The following is a description of a gene set: Mouse Gene Set: CUI_TREG_IL1A_RESPONSE_DN Cytokines mediate cell-cell communication in the immune system and represent important therapeutic targets. A myriad of studies have highlighted their central role in immune function, yet we lack a global view of the cellular responses of each immune cell type to each cytokine. To address this gap, the authors created the Immune Dictionary, a compendium of single-cell transcriptomic profiles of more than 17 immune cell types in response to each of 86 cytokines (>1,400 cytokine-cell type combinations) in mouse lymph nodes in vivo. A cytokine-centric view of the dictionary revealed that most cytokines induce highly cell-type-specific responses. For example, the inflammatory cytokine interleukin-1β induces distinct gene programmes in almost every cell type. A cell-type-centric view of the dictionary identified more than 66 cytokine-driven cellular polarization states across immune cell types, including previously uncharacterized states such as an interleukin-18-induced polyfunctional natural killer cell state. Genes negatively differentially expressed in cell type: Treg upon treatment with cytokine: IL-1α in mouse lymph nodes in vivo. from publication Cui A, Huang T, Li S, Ma A, Pérez JL, Sander C, Keskin DB, Wu CJ, Fraenkel E, Hacohen N (PMID 38057668) studied in species Mus musculus, and this is the list of marker genes: Shisa5, Nav2, Sh3bgrl3, Tmbim4, Ifi203, Ctss, Rgs10, Lbh, Cd44, St8sia4, Tnik, Jun (jun proto-oncogene), Dbp, Clec2d, Nsg2, Tspan32, Cyth4, Dnmt3a, Trbc2, Arhgef1, Lsp1, Tsc22d4, Ypel3, Ptpn18, Id3, Gm2a (NCBI Gene Id 552880), Dgkz (diacylglycerol kinase zeta), S100a6, Zbtb7b, Tmsb10, H1f2, Acap1, Tgfbr1, Pou2f2, Crip1, Btg2, Arhgap45, Mbp, Fxyd5, Capg, S100a11, Nrp1, Acyp1, Rac2, Bin2, S100a10, Limd2, Tesc, Lck, Hspa1b, Pycard (PYD and CARD domain containing), Ccdc88c, Bcl2, Ltb, Ptpn6, Sh3kbp1, Ipcef1, Ptms, Msn, Itgal, B4galnt1, Apol9b, Mbnl1, Ptpn7, Ikzf2, Vim, H2aj, Macf1, Hnrnpf, Pfn1 (profilin 1), Dguok, Coro1a (NCBI Gene Id 16902), Lamtor4 (NCBI Gene Id 66096), Hivep3, Ahnak, Rasgrp1, Larp1b, Hsd11b1, Abcg1, Pglyrp1, Mxd4, Lgals1, Adgre5, Ms4a6b, Grap, Ptger4, Rgs3, Fos, Rasgrp2, Smpdl3a, Ccnd2, Itgae, Cd69, Cd83, Ms4a4b, Cdc42ep3, Rad50, Capn3, AI504432, S100a4, Gprin3, Ssbp3, Cd28 (CD28 antigen), Cd3g, Apbb1ip, Rabgap1l, Septin9, Ankrd44, Socs2, Vasp, Cd52, Anxa6, Timp2, Tespa1, Stap1, Smc6, Csk, Itgb7, Itgb1, Lrrc8c, Arhgdib, Ighm, Hcst, Ptprcap, Ephx1, Rgs16, Septin1, Thy1, Skap1, Paxx, Arhgef3 (NCBI Gene Id 71704), Elmo1, 9930111J21Rik2, Ski, Grk2, Tbc1d10c, Emp3, Lrrfip1, Lnpep, Hspa1a, Chd3, Gpsm3, Scd2, Slamf6, Ramp1, Cd84, Actn1, Klf6, Klf2, Cotl1, Dynll1